The following is a description of a gene set: studied in species Homo sapiens Binds to and stops, prevents or reduces the activity of a cAMP-dependent protein kinase. Human Gene Set: GOMF_CAMP_DEPENDENT_PROTEIN_KINASE_INHIBITOR_ACTIVITY, and this is the list of marker genes: PKIB, PPP1R1B, PRKAR2B, PRKAG2, PRKAR1B, PRKAR1A, PKIG, SMO, PRKAR2A, PKIA